The following is a description of a gene set: studied in species Mus musculus Cytokines mediate cell-cell communication in the immune system and represent important therapeutic targets. A myriad of studies have highlighted their central role in immune function, yet we lack a global view of the cellular responses of each immune cell type to each cytokine. To address this gap, the authors created the Immune Dictionary, a compendium of single-cell transcriptomic profiles of more than 17 immune cell types in response to each of 86 cytokines (>1,400 cytokine-cell type combinations) in mouse lymph nodes in vivo. A cytokine-centric view of the dictionary revealed that most cytokines induce highly cell-type-specific responses. For example, the inflammatory cytokine interleukin-1β induces distinct gene programmes in almost every cell type. A cell-type-centric view of the dictionary identified more than 66 cytokine-driven cellular polarization states across immune cell types, including previously uncharacterized states such as an interleukin-18-induced polyfunctional natural killer cell state. Mouse Gene Set: CUI_CDC1_IL5_RESPONSE_UP from publication Cui A, Huang T, Li S, Ma A, Pérez JL, Sander C, Keskin DB, Wu CJ, Fraenkel E, Hacohen N (PMID 38057668) Genes positively differentially expressed in cell type: cDC1 (conventional dendritic cell type 1) upon treatment with cytokine: IL-5 in mouse lymph nodes in vivo., and this is the list of marker genes: Plbd1, Ccdc86, Ly6a, Irf7 (interferon regulatory factor 7), Pnp